Given this list of marker genes PACS2, HMGN3, FSTL4, ZNF609, SH3PXD2B, SLC25A37 (solute carrier family 25 member 37), FBXL20, PPM1M, SYS1, HLF, JPH4, FHIT (NCBI Gene Id 2385), MACC1, MOSPD3, GABBR2, PRKN, PDE3A, GLG1, MAPKBP1, NFASC, SLC30A7, SSR1, PIK3AP1, YPEL1, ZBTB21, SOX6, SLC43A2, CKMT2, CNOT2, SLC24A2, KCNA1, PARD3B, ZNF672, ZC4H2, RHOA, PITPNM2, MFSD14B, SCN4A (sodium voltage-gated channel alpha subunit 4), BACH2, NUCKS1 (NCBI Gene Id 64710), EFNA1, STEAP2, ESRRG, VDR, HDGFL2 (NCBI Gene Id 84717), RAB3C, CSF1, ATXN1, TUB, MAP3K9, NF2, MBOAT2, CBFA2T2, STARD3, MLEC, STMN2, LHPP, SLC24A3, SLC4A7, RETREG2, ARF3, MORN4, STIM1, NCOA4, GUF1, SLC12A5, CASTOR2, LINGO1, ANKRD63, RANGAP1, IQCJ-SCHIP1, DIP2B, NDUFB4, XPO7, ANK1, SIRPB1, AMFR, MYPOP, ASPHD2, CADM2, NHSL1, CFL2, KCND2, ZBTB47, NR6A1, PDZRN3, MAPK8IP1, GYPE, CAMSAP2, EI24, POU4F1, CBX5, VCL, SV2B, GRIP2, KIAA0930, NSD1, SCAMP2, CDK16, SEMA3F, FAM227A, TRIM33, NECTIN1, GARRE1, DCAF10, PDXK, ANKS1B (NCBI Gene Id 56899), PPFIA2, SPOCK2, CACNA1B, GPR153, ETF1, HAPLN1, MAVS, LIFR, TENT4A, PIM2, TBL1Y, KIF18B, TOM1L2, HS3ST3B1, DEPTOR, VGLL4, ICMT, ARHGAP1, ZDHHC9, ADAMTSL4, C9orf152, TRIO, SLC12A6, SH2B3, VANGL1, ETV6, CAPZA1, ZNF592, ST8SIA2, TMCC1, CCDC80, PCCB, THEM5, MYO15A, THY1, USP9X, RAB9B, PCBD2, VCF2, FAM120C, TNR (NCBI Gene Id 7143), C2orf68, RAB35, IRGQ, TAF9B, STX2, NR4A3, TRAF6, AP1M2, RNF169, RANBP10, PEA15, VIPAS39, PGAM1, HEATR1, PTPN12, ZNF608, COL5A3, FAM47E-STBD1, PFKFB3, WIPF3, SNPH, ASXL1, CTNNA3, CCDC136, TMEM201, CD300LG, YWHAQ, COPS7B, MOB3B, SSH2, BAIAP2, ATP1B2 (ATPase Na+/K+ transporting subunit beta 2), TEAD3, ABCC5 (NCBI Gene Id 10057), here is a description of the gene set: Human Gene Set: MIR940 studied in species Homo sapiens Genes predicted to be targets of miRBase v22 microRNA hsa-miR-940 in miRDB v6.0 with MirTarget v4 prediction scores > 80 (high confidence targets). from publication Chen Y, Wang X (PMID 31504780)